The following is a description of a gene set: Cerebral cortical atrophy Atrophy of the cortex of the cerebrum. species: Homo sapiens Human Gene Set: HP_CEREBRAL_CORTICAL_ATROPHY, and this is the list of marker genes: ADGRV1, MBTPS2, SMC3, PLAA, PCDHGC4, B4GALNT1, TREM2, VPS35, GABRD, GET4, HIVEP2, NCF1, EXOSC2, OPHN1, USH1G, NEXMIF, MT-ND5, ALDH18A1, TSEN54, TARS1, NDE1, MT-ATP6, MT-TS2, GOLGA2, TOMM40, BICD2, NDN, HEXB, MT-ND1, NEK1, CISD2, TMEM106B, VARS1, AP4E1, LRRK2, ATPAF2, SLITRK2, AP4M1, SQSTM1, SLC39A4, EHMT1, RNF113A, HSD17B10, TRAPPC9, NDP, KCNT1, MT-TF, MT-TH, PRNP, LIMK1, CASK, ATP8A2, CNKSR2, KRAS, USH2A, TTC19, RNU4ATAC, RAB3GAP2, DKC1, FA2H, ERCC5, PGAP1, TRAPPC6B, ELOVL4, EIF4H, AMPD2, CTSF, EXOC7, CHCHD10, B3GLCT (NCBI Gene Id 145173), GRN, PIGN, APP, MYO5A, H3-3A, GON7, NUP133, SLC35C1, DNAJC30, ACTB, CIB2, FMR1, CIZ1, ATP5F1E, PLK4, CLP1, MEF2C, CDC42, MAGEL2, BCAP31, MT-ND6, ESPN, RNF125, WFS1, RARS2, PIGS, GLYCTK, GBA1, KDM6A, POLG2, DGUOK, RAB18, CWC27, MPLKIP, TMEM70, LIPT2, BICRA, SORL1, CHMP2B, VPS13C, SETBP1, RNU4-2, DOCK7, RERE, EIF2B4, TERT, TRRAP, GTF2I, MAF, VRK1, ATP5MK, TBL2 (NCBI Gene Id 27203), IKBKG, KDM5A, PPP2R2B, EMX2 (empty spiracles homeobox 2), HERC1, CLCN4, MMP23B (matrix metallopeptidase 23B), POGZ, AFG2A, DYRK1A, GTF2IRD1, PRKCZ, SACS, ATXN2, FKRP, ATP5F1D, OTUD6B, MT-CO1 (NCBI Gene Id 4512), UBE3A, UGP2, HDAC8, EXOSC8, ALS2, SPEN, USH1C, ADARB1, PIGA, ERCC3, MUC1, MT-CO3, ARX, GIGYF2, FKBP6, UBTF, RMND1, XPA, PDZD7, BAZ1B, PPFIBP1, MAP2K2, TUBGCP6, SNRPN, CACNA1A, GRIA3, EXOSC5, TWNK, PEX7, OCA2, UBE4B, AARS1, TRAK1, RAD21, HSPG2, SLC25A46, CAMTA1, MT-ND4, LUZP1, FGFR1, PDPN, NUS1, GRIA4, METTL27, DDB2, ERCC4, PARN (poly(A)-specific ribonuclease), ZSWIM6, ADA2, PRDM16, ABCA7, TBCD, PAFAH1B1, SNX14, DPAGT1, ERCC2, OCLN, MARS2, GRM7, DNAJC13, EPG5, MT-TQ, GTF2H5, SCO2, MT-TW, KMT2D, PSEN2, ITPR1, ACY1, EXOSC3, TYROBP, MMADHC, RNU12, POLR3A, GRIN1, CPLX1, TAF6, ATP13A2, SMC1A, ATRX, PRDX1, SKI, WHRN, PANK2, TRAPPC12, MAP2K1, VCP, MECP2, TMEM147, GTF2IRD2, POMT1, TUBGCP4, AP1S2, ACD, CARS2, SHQ1, MED11, RHOBTB2, ERCC1, TMCO1, RFT1, PEX1, CTDP1, ZNHIT3, MINPP1, EIF4G1 (eukaryotic translation initiation factor 4 gamma 1), GNAQ, TINF2, BRD4, EXOSC9, MAN2B1, HNF1B, ELN, FARS2, PDE6D, AP4B1, CYB5R3, ALG8, CPA6, PSEN1 (presenilin 1), RTEL1, XPC, TRIM8, SYNJ1, SLC25A15, CASZ1, POMT2, LARGE1, JPH3, CDH23, CLIP2, STX1A, YWHAE, ACTG1, TSEN15, PUS3, SPTAN1, MTRR, PARS2, PIGV, ERCC6, MMACHC, AP4S1 (NCBI Gene Id 11154), MDH2, RNASEH1, POLR3B, BMP4, NDUFA8, PRUNE1, GMPPB (GDP-mannose pyrophosphorylase B), MT-TL1, NIPBL, GNPTAB, CARS1, VPS37D, GPKOW, COG1, AHDC1, PIGL, VPS13A, SPG11, GABRA5, CACNA1E, POU4F1, HIC1, APOE, AGTPBP1, RAB3GAP1, SPG7, MAPT, HRAS, TBK1 (TANK binding kinase 1), STUB1, NOVA2, MT-CO2, TCTN3, GTF2E2, ACO2, BRAF, SCYL2, KCNAB2, PHACTR1, SLC9A6, SNCA, TBC1D20, MT-ATP8, RPS6KA3, PTDSS1, PCDH15, FRMPD4, GDAP2, IARS2, SLC39A8, PYCR2, BUD23, CLN5, BUB1, FBLN1, TMEM270, MVK, GUF1, CYB5A, SIX3, MYO7A, GBA2, RFC2, ATP5F1A